Given this list of marker genes Trpc4, Orai2, Stim2, Trpc7, Orai3, Trpc2, Stim1, Trpc1, Trpc3, Trpc6, Trpc5, Orai1, here is a description of the gene set: Mouse Gene Set: GOMF_STORE_OPERATED_CALCIUM_CHANNEL_ACTIVITY A ligand-gated ion channel activity which transports calcium in response to emptying of intracellular calcium stores. studied in species Mus musculus